Given this list of marker genes HBG1, TFRC, CDCA8, TRAK2, RBM38, ZNF665, TMEM30A-DT, DCP1B, GUSBP5 (NCBI Gene Id 441046), LONRF3, SELENBP1, CENPQ, DPF3, GEMIN2, EIF5AP2, PPME1, SPTA1, BNIP3, TM7SF3-AS1, ERMAP, TARS2, AMIGO2 (adhesion molecule with Ig like domain 2), DMTN, SLC2A1, TLCD4 (NCBI Gene Id 148534), E2F4, KEL, FLACC1, SLC38A5, ALAD, ACSL6, GCLM, GLRX5, ATG14, ANK1, C16orf95, FMC1, HMGB1P3, NUDT12, HASPIN, ERI2, CROCCP2, VWCE, XK, C17orf99, ICAM4, HMMR, ZNF446, NCEH1, TROAP, ATG4D, SLC25A21, HBM, NOP53-AS1, TOMM5, UBE2Q2P1, DHRS13, ZMAT2, C1orf35, EPB42, ALAS2, FAM117A, MT1G, ADD2, PRDX2, IFI27L1, RIPOR3, BLVRB, PNMT, HEMGN, PIGQ, EXOSC5, XPO7, HBA2, TMCC2, WDR76, EIF2AK1, SLC43A1, SLC7A5, CDH10, ST6GALNAC4, SLC4A1, GUCD1, ZKSCAN8, INTS13, HBA1, FAM210B, CISD2, RIBC2, TMEM14C, DCTN3, DPM2, GALNT6, HMBS, BST1, GYPB, MIMT1, ABCB10, HAGH, RNF26, SLC25A37, H2AC20, GYPA (NCBI Gene Id 2993), MYBL2, LINC00907, POMGNT2, LIPG, CDKN3, RHAG, H2AC8, C6orf226 (NCBI Gene Id 441150), UROS, HBZ, RHD, HTRA2, GYPE, FECH, HBB (NCBI Gene Id 3043), CDK2, SLC14A1, RPL37P2, RPS20P14 (ribosomal protein S20 pseudogene 14), HBG2, SLC6A8, TMEM143, ABCC13, XG, CAT, ZNF101, SLC12A4, AHSP, SLC30A10, here is a description of the gene set: studied in species Homo sapiens Marker genes curated from the annotated cluster as represented in the Descartes Human Gene Expression During Development database. Human Gene Set: DESCARTES_FETAL_MUSCLE_ERYTHROBLASTS The gene expression program underlying the specification of human cell types is of fundamental interest. The study authors generated human cell atlases of gene expression and chromatin accessibility in fetal tissues. For gene expression, the study authors applied three-level combinatorial indexing to >110 samples representing 15 organs, ultimately profiling ~4 million single cells. The study authors leveraged the literature and other atlases to identify and annotate hundreds of cell types and subtypes, both within and across tissues. Our analyses focused on organ-specific specializations of broadly distributed cell types (such as blood, endothelial, and epithelial), sites of fetal erythropoiesis (which notably included the adrenal gland), and integration with mouse developmental atlases (such as conserved specification of blood cells). These data represent a rich resource for the exploration of in vivo human gene expression in diverse tissues and cell types. from publication Cao J, O'Day DR, Pliner HA, Kingsley PD, Deng M, Daza RM, Zager MA, Aldinger KA, Blecher-Gonen R, Zhang F, Spielmann M, Palis J, Doherty D, Steemers FJ, Glass IA, Trapnell C, Shendure J (PMID 33184181)